The following is a description of a gene set: Mouse Gene Set: WP_DOPAMINERGIC_NEUROGENESIS species: Mus musculus Dopaminergic neurogenesis, and this is the list of marker genes: Th, Aldh1a1, Fgf8, Nr4a2, Neurog2, Foxa2, Neurod1, Cdkn1c, Nkx6-1, Ascl1, Msx1, Ddc, Pitx3, Lmx1b, En1, Sox2, Gli1, Slc18a2, Slc6a3, Stat3, Nkx2-2, En2, Otx2, Lmx1a, Ret, Gbx2, Gli2, Shh, Tgfb1, Wnt1